Given this list of marker genes WNK1, CRTAM, FUT7, FUT4, LRP12, RET, CCR7, EXT1, ARTN, NEDD9, here is a description of the gene set: Human Gene Set: GOBP_LYMPHOCYTE_MIGRATION_INTO_LYMPHOID_ORGANS studied in species Homo sapiens The movement of a lymphocyte within the lymphatic system into lymphoid organs such as lymph nodes, spleen or Peyer's patches, and its subsequent positioning within defined functional compartments such as sites of cell activation by antigen.